Given this list of marker genes ZNF516, PUF60, A1CF, SLC12A9, ARL2, GPSM3, TKT, RBBP8, SSBP3, ADAM23, CR1, MOBP, PDPK1, DDX11, H2AC16, MYBPC1, UBAP2L, ATP6V0A1, LRCH4 (leucine rich repeats and calponin homology domain containing 4), MMP9, PABPC1P3, GALNT6, NBN, GSTM1, STXBP6, H2AC18, CLUH, H2BC7, SLC39A4, HGH1, ENPP2, HMGN5, H4C8, GPR27, SLC22A14, MAD1L1, RNF170, NCBP3 (NCBI Gene Id 55421), TCP10L, PKD1, ZDHHC11, EPHB4, SLC1A1, CPA2, VARS1, BAZ2B (NCBI Gene Id 29994), TCFL5, NUP214, IER3, DKK1, KCNN4, PRKDC, FAM13A, JCHAIN, OPN3 (opsin 3), CLCN5, FKBP1A, KLF4, SLC22A5, XDH, TBC1D10B, GRHPR, SCRIB, ACVR2B, SAP25, FAM53B, TRIM45, UGT1A10, TSHB, NAAA, MRPL23, SNTA1, NCAPG2, GNRHR, CPNE3, NAPA, BOP1, PCGF2, ENO1, MMP19, DRD2, SNORA70, RHBDD3, H4C7, LARP1, DAAM1, RNASEH2B, PFAS, EIF4EBP1, CHST4, HSP90AB1, RPL35P8, FARSA, TPT1P8, HFE, RRH, PRMT1, LGALS3BP, PPP1R14D, TRAF3IP2, AMACR, TRIP13, INF2, GPR171 (NCBI Gene Id 29909), RIPK2, ESRP1, ELL3, ADK, RING1, ABHD2, METTL1, SAP30, RPL29P7, RPL18AP16, RPL10L, RPL28, POLD2 (DNA polymerase delta 2, accessory subunit), SF3A2, TRIM52-AS1, LILRA5, FAM131A, KCTD12, EPB41, MPP1, SPON1, RAD54B, ST6GALNAC4, IRS1, ERI3, CSN2, MARCKSL1, RPSAP44, BAALC-AS1, SSX2IP, GIT1, MTDH, TENM1, XKR8, TMEM97, PUS7, CYP24A1, TSPAN2, RPS10P5, PSPH, EPS15L1, H2AC8, COL18A1, TMEM39B, MERTK, MCM7, BPNT2, ANGPTL2, GRN, COMMD10, SOCS6, ZNF593, TGS1, SLC7A8, ANK1, ECT2, JAG2, PPP1R15A, KAT2A, BEX3, RPH3AL, ATP1B1, LRRN3, FCGBP, CBLL1, ENSG00000275616, MEST, KRT18, PEPD, YBX3 (NCBI Gene Id 8531), SOX12, SLC7A6, NDUFA10, ZC3H3, LRRC14, VPS8, TM6SF1, DOCK1, INTS11, MPZL2, PDE7B, TCL1A, PLA2R1, ITGA10, SLC11A1, RMDN1, TCEAL9, GFUS, CAD, IFNGR2, DTX2P1-UPK3BP1-PMS2P11, TPD52, PPP2R5D, PGLS (6-phosphogluconolactonase), KLF6, C15orf39, SORD (sorbitol dehydrogenase), ARK2N, NEDD4L, CDK2AP1, CIC, PAICS, MCM4, CKMT2, INHA, TAF4B, POMGNT1, MCOLN3 (mucolipin TRP cation channel 3), DGAT1, MED12, TSPAN15, SFN, HSD17B8, FXYD3, COL6A2, TP63, ATF3 (NCBI Gene Id 467), MPP3 (NCBI Gene Id 4356), HGF, PIEZO1, NRIP3, GCAT, TSPY11P, CTSH, IFRD2, H2BC9, LYPLA1, FZD6, CRISPLD2, ITM2C, MCM2, H2BC5, BCL7A, CORO1B, H2BC10, IPO4, YIPF4, RAB25, H2BC21, SIX6, HMBS, ZNF177, PML, TRIL, RPL7P27, BTBD8, PARM1, SORT1, MTAP, HKDC1 (NCBI Gene Id 80201), ZNF507, IGKV1D-13, STC2, AK5, ACTMAP, SHTN1, BTNL3, GPR137, GPD2 (glycerol-3-phosphate dehydrogenase 2), AGPAT1, IMPDH2, H1-0, PDIA5, GRM6, PTP4A3, CXCL1 (C-X-C motif chemokine ligand 1), CPSF1, LAMB2, MTSS1, CELSR2 (cadherin EGF LAG seven-pass G-type receptor 2), PTPRO, BCORL1 (NCBI Gene Id 93949), PRMT5, CYC1, TCF7L2 (transcription factor 7 like 2), ALPL, H1-2, CCNG2, SSBP2, CPED1, LSM5, MED31 (mediator complex subunit 31), TLE2, CYP2A6, IGFBP5 (insulin like growth factor binding protein 5), WDR62, BZW2, ERBB3, PDK2 (pyruvate dehydrogenase kinase 2), AKAP6, MCAM, CLIC4, PCLAF, N4BP1, KLHDC10, NCKIPSD, NEO1, CEP112, NEDD4, NTAQ1, H4C5, CTNNA1, MRPL15, CD40, MTFR1, MTERF3, DHFR, ALPP, RPRD1A, CCNB2, PEX6, ROGDI, PITPNA, MPZL1, ZNF280A, GNA11, ALOX5, SLC48A1, SCRG1, ARHGAP32, NPRL3, EEA1, SNTB1, NCDN, CYB5A, CCNB1, HCFC1, FBN2, SCCPDH, ZSCAN12, PGGHG, GGT1, ARHGEF1, RAB1B, ALDH5A1, TRIP10, DDR1, LRRC2, FAXDC2 (NCBI Gene Id 91674), BPHL, NME2, PTK2, H2BC12L (NCBI Gene Id 54145), MKI67, DMWD (DM1 locus, WD repeat containing), LST1, ENTR1, AGA, PCCB, PLPPR1, NCAM2, HOMER3, MYO1B, CRELD1 (NCBI Gene Id 78987), PAPPA2, SLC5A5, ADAMTS3, SCN10A, ACRV1, HEY1, FN1, IGFBP7, BPIFA1, PDE1C, PRIM2, here is a description of the gene set: species: Homo sapiens from publication Dürig J, Bug S, Klein-Hitpass L, Boes T, Jöns T, Martin-Subero JI, Harder L, Baudis M, Dührsen U, Siebert R (PMID 17713554) Human Gene Set: DEURIG_T_CELL_PROLYMPHOCYTIC_LEUKEMIA_UP Genes up-regulated in T-PLL cells (T-cell prolymphocytic leukemia) bearing the inv(14)/t(14:14) chromosomal aberration. T-cell prolymphocytic leukemia (T-PLL) is a rare aggressive lymphoma derived from mature T cells, which is, in most cases, characterized by the presence of an inv(14)(q11q32)/t(14;14)(q11;q32) and a characteristic pattern of secondary chromosomal aberrations. DNA microarray technology was employed to compare the transcriptomes of eight immunomagnetically purified CD3+ normal donor-derived peripheral blood cell samples, with five highly purified inv(14)/t(14;14)-positive T-PLL blood samples. Between the two experimental groups, genes were identified as differentially expressed, including functionally important genes involved in lymphomagenesis, cell cycle regulation, apoptosis and DNA repair. Notably, the differentially expressed genes were found to be significantly enriched in genomic regions affected by recurrent chromosomal imbalances. Upregulated genes clustered on chromosome arms 6p and 8q, and downregulated genes on 6q, 8p, 10p, 11q and 18p. High-resolution copy-number determination using single nucleotide polymorphism chip technology in 12 inv(14)/t(14;14)-positive T-PLL including those analyzed for gene expression, refined chromosomal breakpoints as well as regions of imbalances. In conclusion, combined transcriptional and molecular cytogenetic profiling identified novel specific chromosomal loci and genes that are likely to be involved in disease progression and suggests a gene dosage effect as a pathogenic mechanism in T-PLL.